Given this list of marker genes ZYX, MYL9, LOXL2, YIF1A, TAGLN, TUBA1A, ALDH1B1, CNN1, TUBB6, TPM1, SMYD3, MFAP5, RPL22L1, C5orf46, TUBA1C, PPP1R14B (protein phosphatase 1 regulatory inhibitor subunit 14B), NME1, TNC, TUBA1B, PYCR1, TIMP3, TPM2, PDLIM7, TUBB2A, SEC13 (NCBI Gene Id 6396), CREB3L1, CSRP1, ACTA2, KDELR3, POSTN, NEXN, LRRC59, CKAP4, GJB2, CRABP2, EIF4EBP1, SRM, FSCN1, TNFRSF12A, GLIPR2 (NCBI Gene Id 64148), GLIPR1, IDH2, SUGCT, C12orf75, ACTG2, STMN1, COL11A1, TGFBI, COTL1, LOX, here is a description of the gene set: Genes upregulated in subsets of cells of a given type within various tumors from publication Gavish A, Tyler M, Greenwald AC, Hoefflin R, Simkin D, Tschernichovsky R, Galili Darnell N, Somech E, Barbolin C, Antman T, Kovarsky D, Barrett T, Gonzalez Castro LN, Halder D, Chanoch-Myers R, Laffy J, Mints M, Wider A, Tal R, Spitzer A, Hara T, Raitses-Gurevich M, Stossel C, Golan T, Tirosh A, Suvà ML, Puram SV, Tirosh I (PMID 37258682) species: Homo sapiens In this study, an extensive analysis was conducted to define meta-programs (MPs) capturing intra-tumor heterogeneity across a spectrum of tumor types. The approach utilized non-negative matrix factorization (NMF) to analyze each cell type separately within individual tumor samples. This involved the analysis of malignant cells, macrophages, fibroblasts, endothelial cells, epithelial cells, T-cells, and B-cells. NMF was executed with varying parameter values (K=4, 5, 6, 7, 8, 9), thereby generating 39 programs for each cell type per sample. Each NMF program was summarized by the top genes based on NMF coefficients.\nRobust MPs were then delineated for each cell type using a set of stringent criteria, including recurrence within the same tumor, similarity to programs in other tumors, and non-redundancy within a tumor. Subsequently, these robust NMF programs were clustered (per cell type) based on Jaccard similarity, leading to the identification of MPs associated with each cell type.\nTo enhance the quality of the MPs, a refinement steps were undertaken, involving the removal of MPs suspected of reflecting low-quality data (with an overrepresentation of ribosomal proteins or mitochondrial-encoded genes), single-study inclusion, or similarity to miss-annotated cell types. Human Gene Set: GAVISH_3CA_METAPROGRAM_FIBROBLASTS_MYOFIBROBLASTS